Given this list of marker genes GRM1, RNF13, MAPK11 (mitogen-activated protein kinase 11), HTR5A, CDK5R1, ZNF335, NEFH, SLC35G2, RUNDC3A, SCN3B, DRD2, NPAS4, KCNIP2, PCSK2, ATP6V0A1, HCN3, GABRG2, OMG, BDNF, APBB1, VIP, HTR1A, LHFPL5, POU4F3, STMN2, RASGRF1, DRD3, GHSR, DDX25, KRT86, LHX3, CELF3, NCAN, TRIM9, PRLHR, KCNH4, SLC17A6, CHAT, PRMT3, PHYHIPL, HCN1, NRSN1, POMC, ZNF579, DPH2, RXFP3, SST, CHKA, SLC12A5, TAOK3, ELAVL3, CALB1, SCAMP5, OGDHL, CHGA, AMER3, HHATL, PRG3, PAQR4, SEZ6, BARHL1, FGF12, SNAP25, L1CAM, TLCD3B, MGAT5B, GLRA1, COL5A3, HNF1A, TMEM179, GABRB3, POU4F2, RPH3A, INA, ATP2B2 (NCBI Gene Id 491), CHRNB2, SARM1, FGD2, GRIN1, GPRIN1, GLRA3, HES1, CDKN2B, NEFM, DNER, VGF, SRRM4, GDAP1L1 (NCBI Gene Id 93987), PUS3, PDZD7, CRYBA2, NPPB, BRINP1, PTPRN, SYT4, SYT6, KCNH8, here is a description of the gene set: Human Gene Set: NRSF_01 Genes having at least one occurrence of the motif TTCAGCACCACGGACAGMGCC in the regions spanning 4 kb centered on their transcription starting sites. This matches the REST transcription factor binding site V$NRSF_01 (v7.4 TRANSFAC). species: Homo sapiens